The following is a description of a gene set: Human Gene Set: HP_ABNORMALITY_OF_THE_PERIORBITAL_REGION Abnormality of the periorbital region species: Homo sapiens An abnormality of the region situated around the orbit of the eye., and this is the list of marker genes: FBXL4, WDR4, PRR12, H4C11, DHX30, TCF12, PIK3CD, HBA2, POMP (proteasome maturation protein), HLA-DPA1, PTPN22, KMT2E, MLXIPL, ABCC9 (ATP binding cassette subfamily C member 9), PEX16, CAV1, WDR26, KAT6A, ANLN, NUP93, MYO1E, NCF1, GTF2I, TOE1, PLCE1, TBC1D8B, PEX19, FBXO11, ZIC1, ANTXR1, ASXL3, UBE2A, FBXO31, TMEM270, CDH11, NUP85, MYOD1, PIGA, GPR101 (NCBI Gene Id 83550), NKX2-5, FLNA, EDAR (ectodysplasin A receptor), ARX, PITX2, FHL1, PEX10 (NCBI Gene Id 5192), GATAD2B, PEX12, APOL1, LMBRD2, SUMF1, SETD2, KNSTRN, GJA5, TGFBI, JARID2, TAF1, LRP2, HS2ST1, DHPS, SP7, FOS, SLC35C1, CYP26C1, GTF2IRD2, GRIA3, MAGI2, ZNHIT3, RPS6KA3, MEGF8, CTLA4, EDARADD, ANKRD17, PEX26, MDH1, SEC23A, CAVIN1, ACTG1, CLIP2, POLR3A, PIEZO1, ALK, EXOC2, MAB21L2, EMP2, GATA4, VPS37D (VPS37D subunit of ESCRT-I), HBA1, ZSWIM6, SHANK3, RAB23, NSUN2, BSCL2, POU4F1, DAAM2, FGFR2, LYN, LTBP4, CHD8, VPS33A, PEX6, PHOX2B, CITED2, PSMC3, PAK3, GDF1, RBM10, LIN28B, CAMTA1, NSD2, METTL27, PEX14, STX1A, COL5A1, GATA5, YY1, PSPH, TUBB, KMT2B, CLPB, ELN, GSN, HLA-DPB1, ERCC4, SLC29A3, NEU1, ADAMTS2, FGFR3, RPS23, NPHS1, RBL2, AIP, COQ8B, PHF6, MAP2K2, SPTBN1, BRAF, TNFRSF1A, PDGFRB, ARHGAP24, NUP205, SIK3, GAPVD1, KRAS, ATP6V1E1, NPHS2, LMO1, AARS1, H4C3, COL1A1, SOX11, SPEN, KIF15 (NCBI Gene Id 56992), EDEM3, NRAS, PRTN3, PEX2, PLPBP, CTCF, MYD88, BUD23, NUP37, PPP2CA, DNAJC30, SKIC3, KCNJ8, COL5A2, GHR, EIF4H, PHF8, EDA, PEX11B, SPOP, KCTD1 (NCBI Gene Id 284252), LIG4, CD2AP, FOXG1, PAX2, CRB2, PIK3R1, TRAPPC9, JAG1, CCBE1, BAZ1B, NUP107, DOCK7, HRAS (NCBI Gene Id 338029), EPHB4, PPP1R21, NAA10, TBL2, PPARG, TRPC6, LIMK1, OPHN1, PRMT7, PUS7, RIN2, EFEMP1, FKBP6, FGFR1, SUZ12, NUP133, ZFX, MASP1, YARS1, RBMX, INF2 (NCBI Gene Id 84800), ARHGDIA, LZTR1, SOX4, PEX5, SLC25A24, PSMB4, MED13, GNPTAB, PEX13, XPNPEP2, IGSF3, CHD1, TBX1, PTPRO, MED12L, LAS1L, FTSJ1, PEX3, GTF2IRD1, MAP3K7, MAP2K1, COL4A3, WT1, ANKFY1, TWIST2 (twist family bHLH transcription factor 2), SNX14, HDAC8, KIF11, TASP1 (NCBI Gene Id 55617), ZFPM2 (zinc finger protein, FOG family member 2), NKX2-6, HACE1, KPTN, KDR (kinase insert domain receptor), NUP160, DRG1, SRCAP, IDS, COL11A2, TWIST1, GATA6, SOX18, AP1G1, ACTB, ESCO2, CRELD1, TRIO, SERPING1, PTCH1, H4C5, PTH1R (NCBI Gene Id 5745), NRCAM, SMARCA2, FREM1, PEX1, FRMD4A, GNE, ACTN4, MYCN, AGPAT2, RFC2, SOST, FLT4, IARS2, LBR, PCGF2